Given this list of marker genes Acot7, Oard1, Acot4, Acot11, Cln5, Atxn3, Them7, Hdac11, Ndst2, Sirt4, Hdac4, Ndst1, Mta2, Hdac10, Ndst4, Dtd1, Hdac8, Acot9, Sirt6, Desi2, Ydjc, Abcd3 (ATP-binding cassette, sub-family D member 3), Sirt7, Ing2, Aadac, Macrod2, Desi1, Acsbg2, Acnat1, Acot3, Them5, Hdac1, Adprs, Acot10, Suds3, Hdac6, Acaa2, Pla2g6, Ppt1, Acot13, Hdac9, Sirt3, Acot2, Ucn, Mapk8, Acot6, Hnf4a, Acot8, Pigl, Mier1, Baat, Hopx, Abcd2, Hdac7, Sirt2, Ski, Acot5, Acnat2, Hdac2, Hdac5, Sirt1, Abcd1, Amdhd2, Them4, Mblac2, Acot12 (NCBI Gene Id 74899), Hibch, Ndst3, Ncor1, Mier2, Dtd2, Hdac3, Macrod1, Acot1, Sirt5, Trp53, here is a description of the gene set: Mouse Gene Set: GOMF_DEACYLASE_ACTIVITY Catalysis of the reaction: R-CO-X + H2O = R-COOH + HX, hydrolysis of an acyl group or groups from a substrate molecule. species: Mus musculus